The following is a description of a gene set: species: Mus musculus Mouse Gene Set: GOMF_BASIC_AMINO_ACID_TRANSMEMBRANE_TRANSPORTER_ACTIVITY Enables the transfer of basic amino acids from one side of a membrane to the other. Basic amino acids have side chains with a positive charge at pH 7.3., and this is the list of marker genes: Tmem44, Slc7a3, Slc7a9, Slc22a2, Slc25a2, Slc38a9, Slc15a4 (NCBI Gene Id 101014), Slc47a1, Slc7a1, Slc7a2, Slc25a29, Slc7a7 (NCBI Gene Id 20540), Slc7a6, Slc66a1, Slc38a3, Slc38a4, Slc38a5, Slc25a15, Slc47a2